The following is a description of a gene set: Any host process that results in the promotion of antiviral immune response mechanisms, thereby limiting viral replication. Mouse Gene Set: GOBP_POSITIVE_REGULATION_OF_DEFENSE_RESPONSE_TO_VIRUS_BY_HOST species: Mus musculus, and this is the list of marker genes: Traf3ip2, Parp9, Treml4, Il23r, Selenok, Stat1 (NCBI Gene Id 98183, signal transducer and activator of transcription 1), Sting1, Pycard, Aim2, Eif2ak4, Il27, Zc3h12a, Ptpn22 (protein tyrosine phosphatase, non-receptor type 22 (lymphoid)), Pqbp1, Ccl5, Zdhhc1, Pml, Il12rb1, Trim6, Dtx3l, Rigi, Tomm70a, Sin3a, Zdhhc11, Cgas (NCBI Gene Id 214763), Ercc6, Trim44, Mavs, Il23a, Creb3 (NCBI Gene Id 97162), Hsp90aa1, Il4, Il12b